Given this list of marker genes Hes1 (hes family bHLH transcription factor 1), Mir452, Edn1 (endothelin 1), Pitx2, Sema3c, Jag1, Dicer1, Nrp1, Twist1, Cdc42, Bmp4, Ednra, Bmp7, Eng, Folr1, Hand2, here is a description of the gene set: Mouse Gene Set: GOBP_CARDIAC_NEURAL_CREST_CELL_DEVELOPMENT_INVOLVED_IN_OUTFLOW_TRACT_MORPHOGENESIS studied in species Mus musculus The process aimed at the progression of a cardiac neural crest cell over time, from initial commitment of the cell to its specific fate, to the fully functional differentiated cell that contributes to the shaping of the outflow tract.